Given this list of marker genes GLB1L2, EPB41L3, SPICE1, TINAGL1, CST3, GXYLT1, FBXO41, FGFR3, MUC20-OT1, ZNF195, ZSWIM6, TMEM204, DEAF1, BEST4, DIP2A, AUTS2, EML1, CYP4F35P, ARHGEF6, MR1, IFIT1, ATG4D, DNAJC5, SMAD5-AS1, KLHL21, NAAA, LBH, HOXC13, KIN, MAGEE1, ZNF746, KCNJ5, LRRTM1, MIR570, ENTPD1-AS1, MX1, ERFE, WIPI2, WDR1, FAM95A, WNT7B, MOXD1, CTHRC1, MPRIP, LHX3, KCNS2, ELMO2, ADGRV1, NPIPB3, LONP2, ELFN2, MEG3, CMTM4, TMEM35A, MTSS2, SUSD6, EHHADH, ZNF436, TYSND1, GPATCH2L (G-patch domain containing 2 like), ADCYAP1R1, HEPACAM, ANXA13, MARVELD3, AHNAK2, COL15A1, ADAMTS2, ZBTB5, FAM43B, FYN, PEAR1, CNNM3 (NCBI Gene Id 54786), WFDC5, DGAT1, MYLIP, PLEKHM3, DMTN (dematin actin binding protein), EPB41L4B, ARIH1 (NCBI Gene Id 25820), CIMAP1C, ENO2, ACP5, LONRF3, MSANTD2, CREB3L2, IRF5, EPS8L2, SLC47A1, GLDN, C1QTNF12, GLDC, EGFLAM, ABCC12, S1PR5, ITM2A (NCBI Gene Id 9452), HRAS, FRY, MAP6, CNKSR1, FAM83D, AKR1B10, SMIM43, ZNF672 (NCBI Gene Id 79894), ZIC2, MYMX, JPH3, TMEM52, GAK, B3GALNT2, KDM2A, KISS1R, DOCK4, SHROOM2, ATOSA, LRP5 (LDL receptor related protein 5), GPRC5C, TIMM29, APCDD1, GANC, RFK, KCNK10, CROCC, ZNF655, PLD6, DOC2B, ENTPD2 (ectonucleoside triphosphate diphosphohydrolase 2), USH1C, ADCY1, LOXL1, ANKRD20A5P, CMPK2, PARP16, TFAP2E, EN2, FOXF1, PHF21A, TBC1D31, MLF2, AKAP9, GGT1, GRK3, DUOX2 (NCBI Gene Id 82430), SMAD5, HIP1R, ATP6V0E2, KCNC4, CDT1, ATP2B2, ANKRD20A11P, CNIH4 (NCBI Gene Id 29097), FLG, HLA-DMB, CGAS, CDH24, PLEKHA7, UBXN2A, GRIK3, ADGRG1, NEURL2, ABCC5, DYNC2I2, NTN1, FRK, CEP95, C4A, GABRA4, TXLNA, ACAP3, COL27A1, RAPGEF5, CYFIP2, MAN1C1, ARHGEF40, ZNF570, HES6, AK1, FOXF2, EGR1, HOMER2, RNF166, ADAMTS5, ARFGEF2, GLIS2, BCL2L11, KLHL6, SPRY1, TP53I3, VASN, ESRP2, SCAF4, TMEM144, MAP6D1, ZBTB43, LPAR5, MYO10, PLAAT3, AFF3, HR, ZMIZ1-AS1 (ZMIZ1 antisense RNA 1), FBXL20, CHCHD7, EDDM13, ASB2, PLK5, SYNM, EPHB3, CES1, ASCL1, ENSG00000293341, LGALS7, MEF2A, ITGAM, ANGPT1, ABTB2, CLK3, FA2H, AK3P3, JUNB, FGF13, KCNJ12, DACT1, SLC25A25, FAM162B (NCBI Gene Id 353368), ZNF160, NPNT, TNS1, TBCEL, HOGA1, ATPAF2, WRAP73, USP6NL, SLC25A30, EEIG1, LINC00667, TSC2, BIK, GMCL1, ENSG00000255367, TTC39C, COL6A1, CXCL14, CYP4F3, WNT4, NPIPA1, LINC02754 (NCBI Gene Id 105369360), TRIM71, SORBS2 (NCBI Gene Id 8470, sorbin and SH3 domain containing 2), HBEGF, HHATL, SNORC, CSDC2, RBM4B (RNA binding motif protein 4B), SUN1, RIMBP2, ANK1, FAM182A, SLC22A23, FRMD5, ELL3, GRAMD1B, DOK4 (docking protein 4), TUB, FAM43A, SAC3D1, HVCN1, FAM106A, OGA, ABCG2, ENSG00000237250, ZNF37A, EEF2, TP73, EEIG2, TLCD1, ECE1, CASP10, DSTYK, XAF1, UBE2Q2P1, PRR5L, AGAP1, LAT2, BID, FOXS1, ABCG1, FBLIM1, ZNF283, DIP2C, DIDO1, BMP7, IPP, RHOB, GOLGA7B, EDAR, PRRT3, SH3TC1 (SH3 domain and tetratricopeptide repeats 1), DUSP22, BLMH, MAP7D2, EPPK1, CEL, ENSG00000288081, BRD7, SMPDL3B, SMAD7, CARNS1, MFHAS1, BCL2A1, MSX2, GNA11, RASSF10, MDM2, LAMB4, C6orf132, KCNK3, ADAM12, FYB2, CANT1, MAB21L1, HOXA11, TMEM65, ALG9, SLC30A10, GCH1, CERS4, CSPG4, MEGF11, HILPDA, FAM167A, ARID2, ARHGAP27, ZBTB42, CDIN1, CAMK2B, GNPTAB, MVP-DT, TRAK1, CRIP2, ZGPAT, FGD3, RILPL2, DFFA, CEP164, TOLLIP, ANKRA2, FGD4, GNG11, ORAI1, TRPV2, FITM2, TGS1, PRR22, CYSRT1, VSNL1, ITGA9, INSR, TRAF4, LRRN1, C12orf76 (chromosome 12 open reading frame 76), MTUS2, ZNF451, AGPAT3, CEBPA (NCBI Gene Id 1050), ELMOD1, LRRC57, KIF16B, ZKSCAN1 (NCBI Gene Id 7698), ERO1B, DPYSL4, CCNK, ULBP2, SNX32, SHISA9, UNKL, JPH1, MC5R, TOX, VASH2, BBS1, CNNM4, MEIOC, KCNQ1, ID2, GDE1, ZNF561, GPCPD1, CABYR, EXT2, DPY19L2P2 (DPY19L2 pseudogene 2), GPSM1, ZNF649, FBXO25, AHSA2P, ZNF319, CITED1, ULK1, HEG1, ZNF708, AQP3, LYNX1, ETNK1, KIAA0232, ABHD17C (abhydrolase domain containing 17C, depalmitoylase), ABHD13, CLIC5, SUSD5, MTNAP1, NANOS1, HPS6, BVES, MSL2, BACE1, PLPPR1, PTPRJ, IL1RAP, DEDD2, THEMIS2, COL22A1, MED23, ID4, SLC46A1, ACO1 (NCBI Gene Id 48), TPM4 (NCBI Gene Id 7171), MOSPD1, CRAMP1, CCN4, HIC2, DQX1, LDLRAP1, MCC, EFNA1, BLNK, GRAMD4, SLC25A34, EDEM1, ALDH4A1, LUZP1, FZD1, IRX5, LDB1 (NCBI Gene Id 8861), KRT23, ITPKB, KAZN, CILP, UCKL1, LOXL1-AS1, LTF, GATA3, LRP10, INPP4A, ALDH7A1, MYB, LINC00115, UNC119, LYPD6, NXPE3, KBTBD6, GRM8, NSG1, CARD18, IRF1, IGF2 (NCBI Gene Id 492304), MEGF10, TECPR2, INSM2, ZNF470, DCLK1, SPNS2, TUFT1, ZNF296, DOP1A, MACROD1, DHRS3, UQCC5, METRNL, CACNB3, MBNL1, MIGA2, NLRP1, GDF9, TRIM8, MAML1, SEC14L5, VAMP5, HS3ST3B1, STING1, DUSP13B, APOL6, ESPN, TMEM128, EFNA2, KDM6A, XG, MEGF6, BRINP1, ABCD1, VPS13C, IL2RB, LMBR1L, TBC1D14, MMEL1, CYB561D2, DLX3 (distal-less homeobox 3), GJA3, IL10RA, CIDEB, USP6, DNASE1, GNG2, ZXDC, RETREG3, ZFP62, AIFM2, ADAM23, HOXD10, VWA1, ABR, TRAF3IP1, CDKN1B, ZNRD2, FECH, CELF2, UNC5B, UBE2QL1, GRTP1, MST1, ALDH1L1 (aldehyde dehydrogenase 1 family member L1), AHDC1, LTBP3, UMODL1, DANT2, AKTIP, TOX2, GRAMD2A, ZNF343, ASPA, MCF2L, GHR, IRGQ, LGALS9, KALRN, HIPK3, IGFBP3, ZBTB20, DUOX1, SLC66A1LP, BCOR, FRMD3, EOMES, KCNK7, KRT32, DNMT3B, CNKSR3, COL18A1, ADAP2, ABCB1, SPATA2L, CA10, POLR1A, CHKA, MMP12, GPR143, LRP5L, ASH1L, RNF213, P2RX7, FNIP2, KIAA1671, F8, PLCXD1, CEP85L, FLRT2, ILDR2, ZFYVE1, STOX2, SMIM10L2A (small integral membrane protein 10 like 2A), EMILIN2, CDIP1, HPN, LRRTM2, ZNF304, NOCT, STRADA, TMEM63A, DNAJC18, BRWD1, MXRA5, RTCA, CHRNA7, TGFBRAP1 (NCBI Gene Id 9392), KIAA1217, FYCO1, DNAJC6, KLRK1-AS1, BDNF, ZNF215, NECTIN4, CCDC117, INPP5D, MARCHF2, ACVR1 (NCBI Gene Id 90), MLXIP, LLGL1, MST1P2, EXOC7, ELF4, MYORG, TMEM165, VWCE, SPRING1, TMEM127, KIF3B, ITIH5, MAD1L1, LHX6, SH2B3, FGF11, DAB2IP, TSGA10, EPB41, BEND7, ELOVL3, TNRC6C, UBE2Q1, PDE10A, APOBEC3B, HS3ST6, NKX1-2, APAF1, FGFBP3, SIPA1L2, GLIPR2 (NCBI Gene Id 64148), TRIM7, CRACDL, AFF1, KLHL20, FLI1, SEMA4D, KSR1, KRBA1, WNT11, ZFYVE28, CBFA2T3, ABHD6, DNAAF3, CHRM4, NUAK1, PROSER2, ENPP4, CDHR1, CKB, B3GNT7, FBXL21P, CADM1, DIPK2A, EXO5, DENND2C, PTAFR, EFNA4, CES3, TLNRD1, HECTD4, POLR1H, DVL3, PODNL1, AKAP7, ZNF341, TAF5, LIFR, C2orf88, POLR3GL (RNA polymerase III subunit GL), EME2, CAPN3, FOXL2, ZCCHC24, INTU, SMAD3, ZNF385A, CHST3 (carbohydrate sulfotransferase 3), CEACAM1, FBXO44, FDXR, CCNF, ASPSCR1, SHISA8, GAA, TRAF5, ABHD15, GJB6, CACNA2D2, ABCA13 (ATP binding cassette subfamily A member 13), CACNB2, FGF1, MICAL3 (microtubule associated monooxygenase, calponin and LIM domain containing 3), FAM149A, MXI1, FRRS1, JAG2, PCMTD2, ITSN2, CST11, SYNE3, FAM13C, LY6D, NRARP, KIF26A, TENT5C, EMX2, ZNF30, SLC16A14, FAM184A, KCP, FRZB, USP18, FRMD8, TDRD10, GJD3-AS1, SMAP2 (small ArfGAP2), ACER3, TPST2, GAB1, FADS3, ZNF234, PRAP1 (proline rich acidic protein 1), WNT10A, MYT1, ATP23, RIPOR3, LINC00375, IQSEC1, DZIP1, WEE1, CEP170B, HSPA12A (NCBI Gene Id 9893), URB1, CASP1, TRIM2, ZBTB34, ELAPOR1, ZNF654, VDR, PHRF1, ABCC11, IHH, MFSD9, CHST15, WHRN (whirlin), TRIM73, LINC01666, CYP4F2, ISOC1, OTULINL, PAXBP1, TMEM184C, HDAC5, KLC3, HOXC6, ZNF850, INPP5B, GALNT10, GNG7, FUT1, RIC1, FOXP4, MCOLN2, ARHGEF17, TRIM52, MINDY3, BAIAP3, GALR2, ISG15, DUOXA1, RETREG1, SLC35G2, DNASE1L2, INAVA, DDX31, C11orf96, CLTCL1, KCNG3, HOXA5, ARHGAP23, INTS15, TMCC2, ARAP1, CCDC3, CHST1, ZNF71, BMP2, MERTK, EVC2, CRIP1, TRIM3, MYRF, C7orf57, ABTB3, TMEM243, EVPL, CIPC, CRACD, APC2, F2RL2, DISP1, CAMTA1, ARID1B, KIAA1549, LINC00472, EMILIN3, HS6ST1, ZAP70, FGD5, CSH1, VPS37D, S1PR3, TRIM26, GOLGA8A, ANKRD20A1, DLK1, CX3CL1, INSYN1, LIMK2, MARCHF3, REEP1, LDLRAD4, GSTT2, GNA14, ARK2N, ZNF248, ZNF468, GREB1, HMGB3, RORA, COL21A1, FOXC1, GPC4, BUB3, PGAP1, MON2 (NCBI Gene Id 23041), ABCA7, RIMBP3 (NCBI Gene Id 85376), BLCAP, ZNF777, MAN2B1, KIF26B, ESPNP (espin pseudogene), GDPD5, TUSC1, ZNF398, NEDD9, DUSP19, CEMIP, FGF18, CMBL (NCBI Gene Id 134147), CNTNAP3, ZDHHC9, KDM4B, LIN7A, HSD17B3, KCNJ5-AS1, VCAN, SHISAL1, HOXC5, DIS3L2, PSEN2, CYP17A1, DEPDC7, KIF1B, GATM, ZMAT3, CLN8, GNAS, MINDY1, ARNT2, B4GAT1, MYO6, SMAD6, HPGD, CABP7, PRXL2A, SPTSSA, NOL4L, IL20, ADSS1, TSPYL5, WHAMMP4, FOXC2, MIR29B2 (microRNA 29b-2), ILDR1, SIDT1, COL2A1, KCNJ15, BRPF1, ARRB1, CXXC5, DISP2, IFIT3, ACKR3, LRPAP1, MAP7, LINC00526, CHST2, LRRC8E, ZNF658 (NCBI Gene Id 26149), MAN1A1, SNHG14, MLC1, ACSBG1, HSD17B1, LMO7, ARX, CERS3, RASEF, SOX6, AHSG, SMAD9, BAIAP2, ARL14EP, GABRE, MOB1B, MTCL1, CEP120, FAXDC2, FLNC, ABHD4, EAF1, C16orf87, ZNFX1, WIPF3, KLHL28, ZNF684, CLCN4, RBM41, SPATA18, NATD1, ANK3, ARL8A, DOCK8, CABLES2, EDNRB, H2BC21, BAP1, LPCAT3, LRRC37A4P, CES2, ATP8B1 (NCBI Gene Id 5205), CALML3-AS1, CRYBG2, APOL2, KCNB1, NRG2, HUNK, INPP5E, GPR183, GUSBP1, GAMT, ARHGAP19, GDNF, DLG5, WDR20, TMEM107, TSPAN11, MUC2, ZCCHC8, GPR155, GOLGA8N (NCBI Gene Id 728080), LACC1, NIPAL4, CHAC1, MAGEH1, GRHL2, MEX3B, IRF4, ITPRIPL2, CCS, ZNF12, RTP4, ZNF284, SDHAF1, FCHO2, GPT2, TSPAN14, VPS13B, ENSG00000269825, BCLAF3, MCF2, MCHR1, BTG2, ZNF600 (zinc finger protein 600), GABBR2, WDR47, ADRB2, ZNF20, PLIN4, LINC01719, TREM2, CGNL1 (cingulin like 1), CNGA3, VIPR1, TSPAN33, HSD11B2, DDAH1, CDRT4 (CMT1A duplicated region transcript 4, NCBI Gene Id 94146), DBH-AS1, TREML1, MARK4, INSYN2A, LZTS1, TRAK2, ERVK3-1, HIC1, SMTNL2, FAM83F, NRK, GLS2, ZYG11B, HES2, ANKRD46, DGKZ, CASP6, RMDN2, ASPRV1, CFAP96, C19orf25, WNT7A, IFIH1, GLCCI1, ADO, C1QTNF1, KDM2B, RNF228, FKBP6P2, CCNA1 (cyclin A1), CYBRD1, LTB4R, MN1, KCNIP3, CAMK1, EDNRA, COL9A3, TMEM40, MAF, HAND1, SLC32A1, CAST, TNFAIP8L1, TRIM36, GATA2, ADCY6, GID4, RNF144B, ZFP90, COL5A2, FOXO6 (NCBI Gene Id 343552), BICDL1, FAM83G (NCBI Gene Id 650803), ABCA1, PRRC2B, USP15, ITGAV, POGLUT1, MROH2A (maestro heat like repeat family member 2A), INAFM2, ZBTB48, GALNT18, NRBP2, KLHL3, ZNF420 (zinc finger protein 420), MAFB, PYGO1, ARHGEF4, MANBA, CYP27C1, CFLAR, GRN, CCDC134 (NCBI Gene Id 79879), FBXO34, CRYAB (NCBI Gene Id 1410), ABCA12, CPE, CXADR, MTCL2, ANO4, GALNT12, LRRC37B, POLH, ABCB6, CBX4, CROCCP2, TUBGCP6, GGT6 (gamma-glutamyltransferase 6), OBSCN, EML6, TOR3A, ZNF702P, ADRM1, BGLAP, ZNF786, ANKRD65, ZC3HAV1, GINS4, RBP7, MSX1, GCNT2, RIPK4, CYRIA, ZDHHC11, CAMK2G, PRDM6, GH2, ARG2, IRF2BPL, ECHDC3, KNDC1, HAGH, GRK5, CDKN1C, LIMD1, ZNF440, IL7, GPR37, SHE, COL13A1, RTL10, AMOTL1, MAPK13, LRRC37A, PLIN2, TP53I11, MUC5AC, TSC22D3, BRD1, DUS3L, GALNT11, GASK1B, AGAP3, FUT4, ZNF765, MARCHF8, CNTN2, H2AC11, KRT8, USP35, TRPM6, MICALL2, RNF169, LINC01120, ICAM2, CDKN1A, KIF9, MMP11, MDFIC, CYP2S1, ZCCHC14, GPR157, FAM53B, PIDD1, COL4A4, DOCK8-AS1, H19, CEP43, ONECUT2, SLC7A1 (NCBI Gene Id 6541), SIKE1, TMEM64, TP53INP1, RNU6-37P, GATA5, ZNF275, TTYH2, DHRS2, ETV7, IDUA, EDN2, DEFB1, GSE1, CELSR2, ADM, GAD1, CRISPLD2, ZNF767P, MAP3K14, ARHGAP6, NEU3, RASGEF1A, TLR3, SPRTN, LINC02688, ARHGAP10, ARC, MOAP1, ZNF367, ARHGAP44, WDFY2, ZNF750, FBRSL1, PHLDB3, DRAXIN, MMP28, MIB2, YPEL3 (yippee like 3), ANXA9, GNMT, NAA60, CYP4F11, AATBC, IGF1R, CLP1, ADAMTS7, here is a description of the gene set: p53 and p63 belong to a family of sequence-specific transcription factors regulating key cellular processes. Differential composition of the p53 and p63 DNA-binding sites may contribute to distinct functions of these protein homologues. We used SELEX (systematic evolution of ligands by exponential enrichment) methodology to identify nucleic acid ligands for p63. We found that p63 bound preferentially to DNA fragments conforming to the 20 bp sequence 5'-RRRC(A/G)(A/T)GYYYRRRC(A/T)(C/T)GYYY-3'. Relative to the p53 consensus, the p63 consensus DNA-binding site (DBS) was more degenerate, particularly at positions 10 and 11, and was enriched for A/G at position 5 and C/T at position 16 of the consensus. The differences in DNA-binding site preferences between p63 and p53 influenced their ability to activate transcription from select response elements (REs) in cells. A computer algorithm, p63MH, was developed to find candidate p63-binding motifs on input sequences. We identified genes responsive to p63 regulation that contain functional p63 REs. Our results suggest that the sequence composition of REs could be one contributing factor to target gene discrimination between p63 and p53. Human Gene Set: PEREZ_TP53_TARGETS species: Homo sapiens from publication Perez CA, Ott J, Mays DJ, Pietenpol JA (PMID 17563751) Genes up-regulated in the HMEC cells (primary mammary epithelium) upon expression of TP53 off adenoviral vector.